The following is a description of a gene set: studied in species Homo sapiens Genes up-regulated in peripheral blood mononuclear cell 2m vs 0m in young adults (18-25) after exposure to HPV-16 L1 VLP, time point 2M. Comment: List of DE Genes After Vaccination Using p<0.05 as Cutoff Human Gene Set: GARCIA_PINERES_PBMC_HPV_16_L1_VLP_AGE_18_25YO_2MO_UP from publication García-Piñeres AJ, Hildesheim A, Dodd L, Kemp TJ, Yang J, Fullmer B, Harro C, Lowy DR, Lempicki RA, Pinto LA (PMID 19155521) Human papillomavirus (HPV) virus-like particle (VLP) vaccines were recently licensed. Although neutralizing Ab titers are thought to be the main effectors of protection against infection, early predictors of long-term efficacy are not yet defined and a comprehensive understanding of innate and adaptive immune responses to vaccination is still lacking. Here, microarrays were used to compare the gene expression signature in HPV-16 L1 VLP-stimulated PBMCs from 17 vaccine and 4 placebo recipients before vaccination and 1 mo after receiving the second immunization. Vaccination with a monovalent HPV-16 L1 VLP vaccine was associated with modulation of genes involved in the inflammatory/defense response, cytokine, IFN, and cell cycle pathways in VLP-stimulated PBMCs. Additionally, there was up-regulation of probesets associated with cytotoxic (GZMB, TNFSF10) and regulatory (INDO, CTLA4) activities. The strongest correlations with neutralizing Ab titers were found for cyclin D2 (CCND2) and galectin (LGALS2). Twenty-two differentially expressed probesets were selected for confirmation by RT-PCR in an independent sample set. Agreement with microarray data was seen for more than two-thirds of these probesets. Up-regulation of immune/defense response genes by HPV-16 L1 VLP, in particular, IFN-induced genes, was observed in PBMCs collected before vaccination, with many of these genes being further induced following vaccination. In conclusion, we identified important innate and adaptive response-related genes induced by vaccination with HPV-16 L1 VLP. Further studies are needed to identify gene expression signatures of immunogenicity and long-term protection with potential utility in prediction of long-term HPV vaccination outcomes in clinical trials., and this is the list of marker genes: JAG1, GPR63 (NCBI Gene Id 81491), PFDN1, DSE, CD38, RBMS2, PSMB2, PREP, LTA, GNB5, PTGS2, RAB17, C2, ANAPC10, HBEGF, MT1X, CACNA1A, LNPEP, LMNB1, CCL18, MICB, CFH, LAMP3, MAL, PPEF1, AICDA, IFITM2, GZMA, NDUFV2, SUB1, CDC6, MYBL2, PIP4K2A, SLC25A40, SLC1A4, RFC3, IL1B, NMT1, LDLR, RAPGEF2, DUSP4, TOP2A, GPD2, WARS1, CDC40, VRK2, PSMA5, CDKN1A, HCAR3, CCL20, HOXC11, NDC80, PMS2, BHLHE40, XCL1, BPGM, ZWINT, RRM2, CCL11 (C-C motif chemokine ligand 11), KCNJ2, FPR2, CCL7, PCK2, ISG20, TYMS, CKS2, PSMA2, TSPAN13, TRIM15, GGT5, GMEB1, OXCT1, SERPINA6, LIMA1, CCND2, ATF5, KCNJ15, RFC4, DMD, TSPAN5, ATOX1, CDK7, MMP8, IDO1, DNM1L, CXCL13, NAPG, HP1BP3, PPA1, CD70, AIM2, POLD1, IL5, LGALS2, LAMC2, COL2A1, IL17RB, UCHL5, SDHB, RNF24, CCNB2, CA11, IL6ST, CFB, ALAS1, IGSF3, ACSL1, NEFH, SERPING1, APEX2, NDRG2, TNPO2, ACO2, PLEK, MT2A, LIF, GABPB2, ADAR, GZMB, PSMB9, C5, INHBA, ZNF222, POLA1, KIR2DS5, TRAIP, CLIC5, IL2RA, SLC2A3, GNLY, PSMB5, CXCL11, VDR, CD40, IDH3A, HSD11B1, PLA2G4C, BMAL2, IDI1, GNL2, KIF11, IL15, HRH4, DDB2, CXCL9, IRF2, PIK3R3, PDSS1, RIGI, FANCA, TIMM17A, HLA-DQA1, TLR1, BCL7B, CH25H, IL6, CDC45, CAV3, CYP27B1, HIRIP3, ZNF35, IL21R, NMD3, MPO, KMO (NCBI Gene Id 8564), MLN, BAX, PSMD12, SERPINE1, CKS1B, KIF20A (kinesin family member 20A), PHLDA2, MTHFD2, CCL4, LANCL2, AURKA, CCL19, UCK2, PAICS, APOBEC3G, CDKN3, RBX1 (ring-box 1), VAMP5, C1QB, SHH, CTAGE1, BATF3, TXN, MNDA, ENPP2, PIK3C3, EML4, SOCS1, ATF6, PLAAT4, SLAMF1, CD1B, CSF2RB, AP1G1, PARP11, ZNF267, ALDH1A2, ACOT7, RGS1, SLC22A17, IL3, TNFSF10, TARS1, MAP2, GCH1, EFCAB2, POLR3K, DUSP6 (NCBI Gene Id 1848), NAMPT, THRAP3, CSF2, EBNA1BP2, PDGFA, TMSB15A, GCNT1, RAB13, TBX1, GMNN, ZPR1, GABBR1, IL2, CLIC2, RAB8B, TNF, PCNA (NCBI Gene Id 5111), CCL24, AFF4, TPI1, LUZP4, SRI, CD209, IFITM1, SLC1A5, BUB1, FASLG, CCL17 (NCBI Gene Id 6361), NCAPG, CLEC1A, PALM, AKR1B10, PLK1, IFNG, FSTL3, MPZ, ETS2, FKBPL, QPCT, PDK4, HIVEP3, GAPDH, CASP1, NUSAP1, CENPA, EBI3, INSIG1, IL1RN, CHAF1A, PKIG, MKI67, CCL13, PRC1, HSPH1, APOL1, IL1R2, SLC25A17, MTRR, PHKA1, TRIP13, GTPBP4, OTOR, PGAM1, GART, RUVBL1, SLC2A6, MMP12, TEX13B, CLEC10A, CASP5, MARCHF6, GINS2, MSMO1, MAD2L1, PTGES, IL12RB2, EGF, NTN1, LAD1, DNAJC7, TAP2, CASQ1, P2RY1 (purinergic receptor P2Y1), APOBEC3B, RAD50, PFKP, STAP1, PTAFR, CTSC, ICAM1, COL1A2, MAPK11, SLC39A8, ST3GAL5, GOLM1, KCNN4, CCL23, MT1H, CD1E, ESR1, CDK6, BRCA1, CTLA4, PROM1 (prominin 1), STX2, TLR2, BIRC3, FEN1, CD83, ADAM19, FANCG